The following is a description of a gene set: from publication Ibrahim L, Mesgarzadeh J, Xu I, Powers ET, Wiseman RL, Bollong MJ (PMID 33096892) Genes up-regulated in HEK293T cells overexpressing FLAG-NRF2 species: Homo sapiens Human Gene Set: IBRAHIM_NRF2_UP The NRF transcription factors NRF1, NRF2, and NRF3, are a subset of Cap'n'collar transcriptional regulators which modulate the expression of genes harboring antioxidant-response element (ARE) sequences within their genomic loci. Despite the emerging physiological importance of NRF family members, the repertoire of their genetic targets remains incompletely defined. Here we use RNA-sequencing-based transcriptional profiling and quantitative proteomics to delineate the overlapping and differential genetic programs effected by the three NRF transcription factors. Comparing our data to recent profiling analyses, we create consensus target gene sets regulated by NRF1, NRF2, and NRF3, genetic programs which we determine to be differentially regulated in human tissues. Together, our data provide a quantitative assessment of how NRF family members sculpt proteomes and transcriptomes, essential information for future studies evaluating the role of NRF factors in normal physiology and disease., and this is the list of marker genes: RCN1, KIF3B, PITHD1, MAPK6, ARL5A, TRIM44, TWSG1, ME1, FBXW10, TFE3, YARS1, KPNA1, HKDC1, SPART, NUP43, SLC48A1, SSB, CMAS, VPS54, HSPA4 (heat shock protein family A (Hsp70) member 4), TRIB3, SLC30A5, XPOT, SRP72, EARS2, BRD7, RAB21, CFAP97, PPP1R15A, NSUN3, ATMIN, TOR1B, GHITM, SYNJ2, TMEM209, SUPV3L1, TOMM34, YME1L1, REPS1, DYNC1LI1, TM9SF2, FTL, DNAJA1 (DnaJ heat shock protein family (Hsp40) member A1), NCOA3, ACBD3, MAPRE1, EDEM3, RNF6, VAMP7, USO1, CEP20, RAB14, TMEM87A, NCL, TLR1, PSMC1, EIF2A, TNFRSF12A, SCFD1, TVP23C, CSNK2A2, AKR1C2, CTBS, TYW3, CSNK1A1, PPP3R1, ZBTB41, TM9SF3, ZNF330, SERP1, TMED5, CD44, CLIP1, PRPF18, NUFIP2, USP10, SET, KIF5B, B3GALNT2, PELO, TRIM16, MIER3, RIT1, CSGALNACT2, WDR43, GFPT1, KIAA0232, ERI1, AKR1B10, HSP90B1, SPX, SPCS2, RB1CC1, OPA1, SRPX2 (NCBI Gene Id 27286), ARL8B, DNAJB9, TRIM4, HPD, RRAS2, EIF3J, SLC1A4, AIDA, VPS41, MAP2, RFLNB, ZNG1B, PIP5K1A, NUMB, SLC30A6, SQSTM1, MTDH, VPS35, SDCBP, TMEM33, ACKR3, LYAR, NRG1, MTMR12, MGST1, CALU, RAB18, STK40, UBQLN1, ATP11B, SLC25A32, TALDO1, ATP10D, VDAC2, PSMD12, STARD7, BCL2L13, RRAGD, STK24, SRXN1, RXYLT1, AMFR, LPGAT1, LINC00942, AKR1C3, STYK1, RGS20, AKR1C1, GCLC, TXNRD1, ZNF426, SNAPC3, UTP15, SLC16A7, HSPA8 (NCBI Gene Id 3312), NAA30, GARS1, DNAJB11, TTC17, CCT7, SLC3A2, TMED10, RUSC2, NOCT, WASHC2C, DESI1, SEH1L, SLC39A6, BAG2, HSPA9, CBR1, MARS1, NIPA2, SSR1, MERTK, ADI1 (NCBI Gene Id 55256), RAB5IF, LMAN1, GTF2E2, ENTPD7, ACAP2, C22orf23 (chromosome 22 open reading frame 23), PPP2CA, ABCB1, METAP2, TIMM17A, SLC7A11, PSMD11, TMTC1, ENOX2 (NCBI Gene Id 95974), SLC1A5, EID3, STX3, IKBKG, RIMOC1, ETF1, PRDX6, NUP153, EXOSC3, NEK4, FAF2, TRIM54, ZBTB20, PHAX, USP46, MRNIP, FXR2, SUCO, DNTTIP2, LSG1, TUBB3, ZNF697, GLA, NLN, RWDD2B, RAB1A, RBM27, M6PR, TMED2, AGFG1 (NCBI Gene Id 3267), MRPS30, DGKG, SHC1, PDIA3, AFG3L2, PHC1, BPNT2, MAFG, PPP4R3B, STT3B, MFAP3, ZNF148, STRN3, SLCO2B1, PGD, NQO2, GOLM2, GFPT2, SRP54, PPM1B, MSANTD3, DDX21, DENR, STIP1, YES1, CMPK1, NOLC1, MAK16, ANXA7 (annexin A7), NXPE3, GOLGA4, HSPA5, RNF8, ACTR3, PAPOLA, CTSL, TNIP3, SLC38A6, OSGIN1, NFE2L2, SLU7, SLC6A15, YWHAB (tyrosine 3-monooxygenase/tryptophan 5-monooxygenase activation protein beta), EIF2S2, AVEN, RNF11, PITPNB, CUL2, FECH, EIF4G2, FKBP14, SRPRB, ATP1A3, KIF2A, SEL1L3, MAN1A2, CLCC1, SEC23B, ARRDC4, SCCPDH, F2RL2, FERMT2, AIFM2, ETV5, B4GALNT1, IFRD1, CUL3, WASHC2A, CSDE1, MFSD12, ALDH1L2, ZNF189, TMT1B, ZRANB2, HMOX1, SPANXA2, ODC1, CCDC47, TGS1, CLIP4, TMBIM6, UBA6-DT, GGNBP2, PRDX1, SPTY2D1, TFRC, PLAA, GFM1, ABHD4, TUBA4A, SERPINE2, SARAF, G6PD, TICAM2, PACC1, USP38, CCT5, NAA50, ARPC2, FBXO28, LRP8, AK4 (adenylate kinase 4), FXR1, FYTTD1, OXCT1, SFMBT1, ABCC4, PAFAH1B2, CORO1C, PRKCI, HBS1L, KIAA1191, TAF5, MCUR1, ATXN10, CTNNBL1, SLC7A5, PPT1, MLH3, ASPH, NQO1, YIPF6 (Yip1 domain family member 6), ABCD3, GPR89A, OTULIN, HTATIP2, DESI2, SPATS2, HSPB8, MAP1A, EPDR1, AIRIM (AFG2 interacting ribosome maturation factor), SLC39A14, ESF1, CSNK1G3, ANKRD42, AP3S2, RPS6KC1, SLTM, NCKAP1, CEP85, PGGT1B, SERINC3, EIF5, TMED7, ASAP2, GNAI3, KIF21A, ZPR1, SYT2, ZDHHC18, IDE, GPATCH2L, ASNS, GCLM, WWP1, MORC4, KCMF1, NUCB2, SPP1, RANBP9, ISY1, CEP290, CLINT1, BACH1, GPAT3, ACSL1, RFFL, MROH7-TTC4, CANX, TAF4B, FAM91A1, SLC7A11-AS1, SMG8, BLOC1S5-TXNDC5, DNAJC10, MEF2A, GNPDA1, UGDH, BMP6, ARCN1, FBXO30, RNF216, ABRAXAS2, PIR, APCDD1L-DT, IL6R, TMEM39A, RARS1, SLC41A2, IDS, ETFDH, SNW1, LUCAT1, MTPN, EPB41L4B, TSR1, ARFGEF1, RTN4, ZEB1, CLU, RBM19, ITCH, NRCAM, FNDC3A, GNA13, SLC12A8, MANF, DKC1, PTDSS1, KEAP1, CCSAP, PRECSIT, NR0B1 (nuclear receptor subfamily 0 group B member 1), MSN, HSP90AB1, UNKL, SGTB, IL27RA, TMEM168, VEZT, RPAP3, OSBPL11, BCAP31 (B cell receptor associated protein 31), CCT6A, CCDC59, AHSA1, DNAJC3, TRIM16L, MTIF2, AHCYL1, CUL1 (cullin 1), LIFR, RPL7L1, ACER3, RAB10, SULT1A1, MTHFD2, KCTD20, ALDH2, GBE1, PRKAR1A, PTP4A2, SLC16A1, ZZZ3, PPP2CB, PNPLA8, PRPF40A, NCOA7, AFTPH, FTH1, DNAJB4, WDR26, NECAB3, GSR, ERP44, CEBPG, HSPA13, FUBP3, PEX19, UCK2, RABEP1, EIF3D, SENP2, PEA15, GTF3C3, VDAC1 (voltage dependent anion channel 1), NSUN2, NARS1, TLK2, KTN1, NOL10, CLIC4, ZNF678, E2F6, UBC (ubiquitin C), MICU2, CDC123, MYC, BAG3, FOSL1, ARMT1, IDH3A, GABPB1 (GA binding protein transcription factor subunit beta 1), BTBD10, BRAP, LRRFIP2, NBN, ASF1A, SLC35F2 (solute carrier family 35 member F2), RPS6KB1, WARS1, UBE2K, MORF4L1, SDE2, LRP12, TARS1, ANXA5 (annexin A5), DNAJC7, BLTP3B, SAMD8, KIF14, GALNT1, TNFRSF1A, ERO1A, TMOD3, CBFB, DCTN4 (dynactin subunit 4), TOR1AIP2, GABARAPL1, PPIL4, CARS1, TBK1, KPNA4, RNF10, PREPL (NCBI Gene Id 9581), SUZ12, STAU2